The following is a description of a gene set: Human Gene Set: GOBP_AZOLE_TRANSMEMBRANE_TRANSPORT studied in species Homo sapiens The directed movement of azoles, heterocyclic compounds found in many biologically important substances, across a lipid bilayer, across a membrane., and this is the list of marker genes: SLC22A1, SLC19A3, SLC66A1 (NCBI Gene Id 54896), SLC38A5, SLC28A2, SLC47A1, SLC38A3, SLC25A29, SLC19A2, SLC22A2, SLC15A4 (solute carrier family 15 member 4), SLC28A1, SLC25A19, SLC7A1, SLC44A4